The following is a description of a gene set: Endocytosis of a protein that requires the substrate to be modified by ubiquitination. Several plasma membrane proteins, including cell surface permeases and some receptors, are targeted for internalization by endocytosis, and are thereafter delivered to the vacuole or lysosome, where they are degraded. Mouse Gene Set: GOBP_UBIQUITIN_DEPENDENT_ENDOCYTOSIS studied in species Mus musculus, and this is the list of marker genes: Grb2, Eps15, Il10ra, Egf, Neurl3, Cbl, Spry2, Sh3kbp1, Vps28, Tsg101, Egfr, Neurl1b, Ndp, Lrsam1